The following is a description of a gene set: studied in species Mus musculus Enables the transfer of an ion from one side of a membrane to the other, driven by the reaction: ATP + H2O = ADP + phosphate. Mouse Gene Set: GOMF_ATPASE_COUPLED_ION_TRANSMEMBRANE_TRANSPORTER_ACTIVITY, and this is the list of marker genes: Atp6v1e1, Atp6v1h, Atp5f1b, Atp6v1g3, Atp6v1g1, Atp6v1c2, Atp6v1b1, Atp6v1b2, Atp6v0a4, Atp6v1d, Atp6v1g2, Atp6v0e2, Atp6v0c, Atp6v0d1, Atp6v1c1, Atp6v1f (ATPase, H+ transporting, lysosomal V1 subunit F), Atp6v0e, Atp6v1e2, Atp6v0d2, Atp6v0a2, Atp6v0b, Atp6v0a1, Atp6v1a